Given this list of marker genes PEX13, EVC2, TRIP13, ORC6, ARVCF, SMAD4, HCCS, BCOR, NDUFB11, EPG5, APC2, PSMB10, COG1, POR, RPS7 (NCBI Gene Id 6201), MED12L, TINF2, RPL5, FOXC1, TYMS, SMARCE1, RPS19, SOX11, WNT4, KAT6B, SMC1A, PEX26, RTEL1, COL3A1, PALB2, TUBB, PEX11B, COLEC10, NOTCH2, GATAD2B, RPL27, KMT2D, REST, NDUFB7, MED12, B3GLCT, ZNF699, ATRX, RPL9 (NCBI Gene Id 6133), SYNGAP1, FANCA, CDC42BPB, MCTP2, COMT, NEB, C2CD3, SIX6, CDC45, USP9X, MYH3, ARX, UBE4B, HIRA, ARID1A, TTC8, NSD1, UFD1, SIN3A, TMEM63A, KAT5, NKX2-1, ADA2, PCNT, TP63 (tumor protein p63), EVC, ERMARD, NHP2, RPS28, MAD2L2, TERT, TRIM8, GRIP1, FGFR2, CILK1, RPS27, EFNB1, FANCD2, SIAH1, SMG8, PAX6 (NCBI Gene Id 5080), ZMYM3, PIGG, RPL35, KDM6A (lysine demethylase 6A), RNU12, KANSL1, CEP152, MBTPS2, RERE (NCBI Gene Id 9642), HES7, TFAP2A, GLI3, OGT, CYP21A2, ARL6IP6, TAF6 (TATA-box binding protein associated factor 6), LETM1, BDNF, WWOX, NPM1, WASHC5, SPTBN1, SMCHD1, B9D2, BRAF, BUB1B, CLMP, PUF60, PQBP1, SOX4, KDM5B, MESP2, CDH11, MYRF, SUCLG1, PDPN, PEX5, DPF2, PRKACA, DVL3, OTUD5, ERCC4, TCF12, WDR35, ACTA1 (NCBI Gene Id 58), PEX12, SCUBE3, CYP17A1, RPL35A, HYLS1, DLL3, SOX9, RPL8, RTTN, SRCAP, DVL1, HSPG2 (NCBI Gene Id 7796), SALL1, DKC1, WRAP53, RPL26, VAMP7, BBS2, DHCR7, CASZ1, FGFR1, WNT5A, ARCN1, LSS, PIGA, GLI1, SMARCA4, PEX16, MAP2K1, RPS29, ORC4, FRAS1, EP300, DYRK1A, FGD1, NOP10 (NCBI Gene Id 55505), ATP6AP2, PARN, SMARCA2, H19, FOXF1, COX7B (NCBI Gene Id 1349), PEX3, SRD5A2, ESCO2, COLEC11, SLX4, CHRNA3, HMGA2, BRD4, USB1, SKIC3, FBXL4, SMC3, ZMPSTE24, FANCF, AFF4, PPP1R12A, FANCB, EHMT1, CUX1, KIF7, RBBP8, LIG4, MECP2, POLE, HOXA13, PEX14 (NCBI Gene Id 5195), CDC42, SEC24C, HDAC8, MAX, KIFBP, FANCI, PRDM16, GNA11, MTM1, PTPN11, FIG4 (FIG4 phosphoinositide 5-phosphatase), PSPH, TERC, RREB1, RSPO1, PEX6, NR0B1, JMJD1C, FREM2, OBSL1, PRKCZ, CDKN1C, SETD5, CDT1, GP1BB, HNF1B, POLR3A, SETBP1, DYNC2LI1, KLHL41, UBE2A, ARID2, BICRA, NAA10, TMEM70, RAF1, THOC6, NDUFA8, FANCG, NR5A1, WBP4, PSMD12, NDUFA6, RPS10, PEX19, CDCA7, MYMK, KLF1, MED25, KDM1A, GATA1, ANKRD11, PIGN, MAB21L1, ARID1B, WNT7A, MID1, NELFA, KCNAB2, RPL15, MKKS, H4C11, VPS35L, PUM1, MMP23B, DCHS1, SMARCB1, ALG12, BRIP1, LRPPRC, RPS17, DHX37, SOX2, PDE4D, MYMX, CYB5A, MAP3K1, ZMIZ1, ZFX, HBA2, MAPRE2, RPS15A, ZEB2, RPS26, PEX2, GABRD, TAPT1, STAR, PLAG1, PITX2, WT1, SRY, NSD2, CDC6, SLC31A1, LMOD3 (NCBI Gene Id 56203), SLC25A10, RPL18, KDM3B, KIAA0586, CARS1, FGFRL1, BRCA2, CCDC22, FAT4, TBX1, TMEM94, BRCA1, TSR2, RLIM, CYP11A1, HOXD13, CUL7, RAD21, PNPLA6, GMNN, GPC3, ISL1, HBA1, ZFPM2, HUWE1, GRB10, ADAT3, DIS3L2, UBE2T, LFNG, ACBD6, IGF2, RPS24, PEX10, GATA4, PIEZO2, CHRNG, LMNA, CCDC8, SPEN, ORC1, PRKACB, TRIM28, SAMD9, CPLX1, FDFT1, FANCC, VAC14, CSPP1, HSD3B2, CUL4B, PAICS, DPYSL5, RPL10, CREBBP, RIPPLY2, ABL1, RPS20, RPL11, SMARCC2, GPC4, ATR, PTDSS1, FANCM, NIPBL, UBR1, SKI, KLHL40, HEATR3, CTBP1, UBA1, PRPS1, SMS, SMARCD1, FOCAD, ROR2, POU6F2 (POU class 6 homeobox 2), FLNA, NDUFS4, MAB21L2, FZD2, AR, DNAJC19, FANCL, DPP9, MAMLD1, RPL31, DACT1, RFWD3, FANCE, MTOR, CTC1, ZMYM2, RAD51C, SSR4, NSUN2, HNRNPH1, KIAA0753, RAC1, PEX1, TONSL, RAD51, XRCC2, LUZP1, TBX22, KRAS (NCBI Gene Id 3845), here is a description of the gene set: Human Gene Set: HP_DISPLACEMENT_OF_THE_URETHRAL_MEATUS A displacement of the external urethral orifice from its normal position (in males normally placed at the tip of glans penis, in females normally placed about 2.5 cm behind the glans clitoridis and immediately in front of that of the vagina). studied in species Homo sapiens Displacement of the urethral meatus